Given this list of marker genes Cxcl12, Megf8, Vegfa (NCBI Gene Id 22339, vascular endothelial growth factor A), Sema5a, Dscam (NCBI Gene Id 78761), Bmpr2, Nrp1, here is a description of the gene set: Any process that activates, maintains or increases the frequency, rate or extent of axon extension involved in axon guidance. species: Mus musculus Mouse Gene Set: GOBP_POSITIVE_REGULATION_OF_AXON_EXTENSION_INVOLVED_IN_AXON_GUIDANCE